Given this list of marker genes Tcp1, Cct2 (NCBI Gene Id 12461), Cct4 (chaperonin containing TCP1 subunit 4), Wrap53, Dkc1, here is a description of the gene set: studied in species Mus musculus A process in which a small Cajal body-specific RNA is transported to, or maintained in, a Cajal body. Mouse Gene Set: GOBP_SCARNA_LOCALIZATION_TO_CAJAL_BODY